Given this list of marker genes NEIL1, XRCC1, LIG3, PNKP, NEIL2, POLB, OGG1, here is a description of the gene set: APEX1-Independent Resolution of AP Sites via the Single Nucleotide Replacement Pathway Human Gene Set: REACTOME_APEX1_INDEPENDENT_RESOLUTION_OF_AP_SITES_VIA_THE_SINGLE_NUCLEOTIDE_REPLACEMENT_PATHWAY studied in species Homo sapiens